The following is a description of a gene set: Blockage of the retinal artery, generally associated with interruption of blood flow and oxygen delivery to the retina. species: Homo sapiens Human Gene Set: HP_RETINAL_ARTERIAL_OCCLUSION Retinal arterial occlusion, and this is the list of marker genes: MYOC, HBB, ADA2, CYP1B1, EFEMP1